Given this list of marker genes Psmb9, Psmb10, Psma8, Psmb8 (NCBI Gene Id 16913), Psme4, here is a description of the gene set: species: Mus musculus Mouse Gene Set: GOCC_SPERMATOPROTEASOME_COMPLEX A proteasome specifically found in mammalian testis. Contains the proteasome activator PA200 in the regulatory particle, and beta1i, beta2i, beta5i and/or alpha4s in the core (20S) subunit. Beta1i, beta2i and beta5i are inducible catalytic subunits, closely related to beta1, beta2 and beta5. Alpha4s is a sperm-specific 20S subunit, but unlike other alternative 20S subunits alpha4s lies in the outer alpha-ring and lacks catalytic activity.